The following is a description of a gene set: Mouse Gene Set: MIR_763 from publication Chen Y, Wang X (PMID 31504780) species: Mus musculus Genes predicted to be targets of miRBase v22 microRNA mmu_miR_763 in miRDB v6.0 with MirTarget v4 prediction scores > 80 (high confidence targets)., and this is the list of marker genes: Ecel1, Erlin1, Rapgef2, Cxcr5, Rprd1a, St8sia4, Scn1a, Padi1, 9430038I01Rik, Stoml1, Sel1l3, Scn3a, Arc, Homer3, Tmem178b, Ppp1r10 (NCBI Gene Id 66450), Plekha7, Snw1, Zfp706, Ndor1, Dusp16, Glcci1, Pja2, Clic5, Ranbp6, Tasp1, Nbl1, Aak1, Shld1, Trappc14, Mprip, Rab7, Ttc4, Pikfyve, Arrdc3, Yars1 (tyrosyl-tRNA synthetase 1), Klf6, Nbea, Stx1a, Pak5, Tead3, Rhoa, Nupr2, Erc1, Sox12, Cd59b, Chd5, Hcar1, Csnk1a1, Tacr1, Rnase10, Mlxip, Rasl12, Ankrd11 (ankyrin repeat domain 11), Epb41l1, Acer2, Pex19, Tgfb1i1, Cep350, Serpinb9c, Kdm4d, Map1b, Otud6b, Clcnka, Rictor, Dnajb1, Tnip1, Fbxo34, Xpr1, Nppc, Stard5, Scn2a, Colec12, Uri1, Nfat5, Gm15816, Rprd1b, Pafah1b1, Gls, Rad51d, Osgin1, Lrrc55, Ppfibp1, Rap1gds1, Stx3, Atp6v1a, Slc29a3, Ephb2, Fam78a, Vps26b, Srf, Celf5, Psmd8, Maob, Bmp5